Given this list of marker genes C16orf89, CDC25B, TPRG1L, UNC119, AK3, ULK1, FBLN5 (NCBI Gene Id 11268), RAI1, ROMO1, THAP11, PRKCB, NDUFS5, TMEM71, CLEC4A, NCOR1, HIGD2A, CPEB2, PTGR1, SPRED2, TSPAN32 (NCBI Gene Id 10077), ZNF7, ABCA1, C2orf76, MKNK2 (MAPK interacting serine/threonine kinase 2), TIAM1, DUSP3, PARP16, TRAPPC2, OARD1, NBEAL2, NDUFB11, PPP1CC, LACTB, SLC45A3, MGLL, PIP4K2A, LAMTOR4, ZMYND11, SMIM19, ITGA6, TMEM176B, ELK3, DAG1, SREBF2, ANP32A, IGFBP3, PIGC, S1PR4, CXXC5, KCNJ10, HLA-DRB1, PODXL, MEF2D, PACS1, SLC48A1, WDR45, ATP1B1, DDRGK1, AP1G2, LOXL1, DERL1, PNPLA7, SNRNP25, TPCN1, ADIPOR2, FCER2, PAPSS1, RAMP1, NRP1, GSN, SUMO3, KLRD1, GAS6, FAM193B, NCBP2AS2, FXYD5, NDST1, SLCO2A1, CCR9, HSD11B1, MXD4, AK1, ANGPTL2, CSRP2, PKD1, LDLRAP1, PLEKHG2, DEPTOR (NCBI Gene Id 64798), GALNT1, ADIPOR1, EVI2B, LTA4H, UHMK1 (U2AF homology motif kinase 1), ALDH2, HEXIM1, PTPRS, ABI3BP, FAM76B, CD74, TSPAN13, CAPNS1, RPN1, ANKRD44, S1PR5, SELENOH, FBXL8, GASK1B, CORO1A, ABHD8, NT5C, PDE2A, HACD4, NRM (NCBI Gene Id 11270), MAPK3, SGCE, MYL12B, PCYOX1, CD84, CAV1, VPS41, SIAE, ACAA2, VKORC1, RAB3IL1, ANKH, GSTM5, CRLF3, APOBR, HDAC5, DOCK2, INPP4A, SMIM14, YPEL3, ZFHX3, ULK2, CDC42SE2, ATRAID, ACAT2, IL11RA, MAST3, RAMP2, TLE5, TPRA1, CNTLN, HAUS8, TNFRSF17, IRAG2, SOX17, TRIM41, MSH6, SIDT2, PITPNC1, CMBL, USHBP1, MMP12, MICAL1, DOCK5, GALNT10, RPS6KA1, MSH2, PARD6G, SPTBN1, PDPK1, COG6, MFGE8, ALDH9A1, MBP, MFAP3, TSC22D1, LMO2, CTNND2, TNK2, ZNF521, LDB1, MED7, ANKMY2, ZSCAN26, DAP, CDC7 (cell division cycle 7), SMC4, HEXB, MCFD2, PRKACA, FMO5, MAPK11, LRBA, PPARG, TGFB1, CAVIN1, KIF1C, ETFBKMT, CAV2, RGS2, CARD10 (caspase recruitment domain family member 10), COL1A1, CHST12 (carbohydrate sulfotransferase 12), MTSS1, S100PBP, RABAC1, GPI, here is a description of the gene set: species: Homo sapiens Human Gene Set: GSE19198_CTRL_VS_IL21_TREATED_TCELL_24H_DN Genes down-regulated in T cells: control (0h) versus IL21 for 24h. Interleukin-21 (IL-21) is a pleiotropic cytokine that induces expression of transcription factor BLIMP1 (encoded by Prdm1), which regulates plasma cell differentiation and T cell homeostasis. We identified an IL-21 response element downstream of Prdm1 that binds the transcription factors STAT3 and IRF4, which are required for optimal Prdm1 expression. Genome-wide ChIP-Seq mapping of STAT3- and IRF4-binding sites showed that most regions with IL-21-induced STAT3 binding also bound IRF4 in vivo, and furthermore, revealed that the noncanonical TTCnnnTAA GAS motif critical in Prdm1 was broadly used for STAT3 binding. Comparing genome-wide expression array data to binding sites revealed that most IL-21-regulated genes were associated with combined STAT3-IRF4 sites rather than pure STAT3 sites. Correspondingly, ChIP-Seq analysis of Irf4_/_ T cells showed greatly diminished STAT3 binding after IL-21 treatment, and Irf4_/_ mice showed impaired IL- 21-induced Tfh cell differentiation in vivo. These results reveal broad cooperative gene regulation by STAT3 and IRF4. from publication Kwon H, Thierry-Mieg D, Thierry-Mieg J, Kim HP, Oh J, Tunyaplin C, Carotta S, Donovan CE, Goldman ML, Tailor P, Ozato K, Levy DE, Nutt SL, Calame K, Leonard WJ (PMID 20064451)